Given this list of marker genes Hs2st1, Wnt9b, Mir217, Six4, Grem1, Hnf1b, Mir216a, Gata3, Gdnf, Osr1, Pax2, Nog, Six1, Mir216b, here is a description of the gene set: Mouse Gene Set: GOBP_MESONEPHRIC_TUBULE_FORMATION The developmental process pertaining to the initial formation of a mesonephric tubule from unspecified parts. A mesonephric tubule is an epithelial tube that is part of the mesonephros. studied in species Mus musculus